Given this list of marker genes MPV17, DZIP1L, ALG9, SLC51B, SLC51A, LIPA, DGUOK, BCS1L, ACADVL (acyl-CoA dehydrogenase very long chain), ANKS6, PKHD1, here is a description of the gene set: Periportal fibrosis The presence of fibrosis affecting the interlobular stroma of liver. Human Gene Set: HP_PERIPORTAL_FIBROSIS species: Homo sapiens